Given this list of marker genes PPP2R3C, COPZ1, PALLD, ZFP91-CNTF, EME1, TK2, PARP10 (NCBI Gene Id 84875), ANTXR2, CDKL3, MRPS22, CTDSPL2, GIPR, MRPL54, PITPNM1, C2orf49, TNK2, CTDSPL2-DT, LARS1 (leucyl-tRNA synthetase 1), COQ10B, MAP2K7, SUB1, APOLD1, ENSA, RPS6, DYRK2, PPIL2, ZFHX3-AS1, EPM2A-DT, WDR54 (WD repeat domain 54), MIR616, CKS2, DSN1, CLIP1, GOLGA3, THOC6, ZSCAN29, ERLEC1, SLC25A23, SECISBP2L, PRDX5, NCOR2, DHRS7B, KATNB1, LINC01954, SEC31A, PARP2, ZSCAN5A, CATSPERG, C2orf49-DT, KMT5C, TPM1-AS, DHX34 (NCBI Gene Id 9704), ZNF628, DYNLT4, LINC02331, RPL37, MIR200CHG, FAM234A, GNRHR2, GABPB1-AS1, IGF2BP3, BRAF, DPY30, FBXL19, LASP1, RACK1, ZFP91, LARP4, PTCD1, SPRED2, GALE (UDP-galactose-4-epimerase), MRPS10, ASNS, TNFRSF1A, TMC3-AS1, TPR, KLHL8 (kelch like family member 8), PPP4R3B-DT, RDM1, LRRC31, NME1-NME2 (NME1-NME2 readthrough), CHTOP, CIC, TNPO3, ODR4, FEM1A, CREB3L4, PRPF38B, MIR200C, PTMA, MBD6, VCP, UNC5B-AS1, CHAC1, MAP3K11, SIK3, PISD, NAA38, SRSF1, TBP, PKIB, ETV6, BSDC1, NEAT1 (nuclear paraspeckle assembly transcript 1), DEPDC4, ERLIN2, TMEM201, TARS1, MIR148A, ZNF646, ZMAT5, NEDD4L, HOXA11-AS, MGAT2 (NCBI Gene Id 4247), LINC01392, IPO8, NAP1L5, TWNK, NCBP2AS2, SRP54-AS1, SNHG21, B9D1, COPG1, MRPS28, DNAJC14, NOTCH3, SLC28A2-AS1, SNORA9, MZT1, ITSN1, GCC1, TMEM198B, GALK2, SH3BP1, NACA, PITRM1, ZNF821, EBAG9, EMC3, CD27-AS1, MITD1, MLF2, FDFT1, BAZ2B, MIR194-2HG, SAMM50, DNASE1, TMEM267, WEE2-AS1, HSD3B7, ATP5MF-PTCD1, CCND2, UBE2Z, NT5C2, CLSTN1 (calsyntenin 1), ZSCAN5A-AS1, CEP70, RNU1-134P (RNA, U1 small nuclear 134, pseudogene), CENPS, UBL5, FOXK2, EIPR1, CNNM4, NPRL2, BRD4, EEF1AKMT3, KLHL28, SNX33, MRPL27, KRT7, WDR59, CCT2, SERF2, HOXA10-AS, SYNE3-AS1, CDC14A, SNHG15, RNU5E-1, ZNF398, SLC35A5, POLR1B, POLR1A, PFKL, AJUBA-DT, EED, PURB, TMCO1, BCAN-AS2, FKBP2, THAP7-AS1, PRR11, PPP4R3B, SRP54, HBP1, NCAPD2, PTPRO, HARS2, SLFN5, ZNF770, PDE4A, MRPL51 (mitochondrial ribosomal protein L51), ATP5MF, ZNF563, RPPH1, PSMD7-DT, UBQLN1, MRPL30, THAP9-AS1, TMED1, BCLAF1, RPS13 (NCBI Gene Id 6207), SNHG1, FBXL12, IST1, ENKUR, ATF6B, WDR75, METTL1, FNTB, LINC00431, MIR141, RPS19BP1, MOV10, MSMO1, ERP29, POC5, ZNHIT1, EPM2AIP1, HNRNPA0, PIGN, SKA2, GDF15, GRM8, LIMA1, BLOC1S2, FBXO30, PEX11B, CENPS-CORT, LRRC46, PCDH1, TRIB1, THAP9, MIR933, DPM1, PTCD3, AJUBA, PLOD3, BTBD19, NCBP2, ESRP2, STARD5, PRORP (protein only RNase P catalytic subunit), SCRN3, MLH1, SDR39U1, MOCS3, THAP7 (NCBI Gene Id 80764), TARS1-DT, TMEM253, ZNF668, ALAS1, RAB11A, MIR3913-1 (microRNA 3913-1), NDUFV3, C12orf76, TMEM18, PRMT2, SLC12A9, IBTK, MSL2, MAP1S (NCBI Gene Id 55201), TSEN2, UPF1, TNFRSF10A (TNF receptor superfamily member 10a), CNTNAP2, DLAT (NCBI Gene Id 1737), MANF, MARCKSL1P1, USP53 (NCBI Gene Id 54532), ABHD2, ARMT1, PPP6R2, HSDL2, ABHD12, H2AC8, CYB561D2, RELCH, FASN, NT5C3A, TRIM11, CAPRIN1, TPI1P2, RALY, SCYL2, C19orf38, RAB30, ATF2, FGGY, POP7, ASB3, ATP13A1 (ATPase 13A1), MCPH1-AS1, SNORD26, ZBTB1, HMGB2, MCCC1, WASL, PSMA2, PPIA, EMC3-AS1, AHCYL1, PRMT5, PLBD1, SLC25A21, RN7SL346P, TBL3, PSMD7, TAPBPL, SOCS5, SNORD25, NME1, EHMT2, RMND1, NDUFS4, AP3S1, ZBED5-AS1, THNSL1, SNORD95, HSPA5-DT, FPGS, GABPB1, SELENOI, RAB30-DT, PGGT1B, JUND, NR1D1, CCDC77, PCNX3, TOGARAM1, MIRLET7IHG, CCDC144NL-AS1, MPV17L2, LINC02026, HARS1, IP6K2 (NCBI Gene Id 51447), ERICH6-AS1, ANKRD17, AIMP1, SSBP1, PRMT5-DT, UBAP2L, IFT70A, DHX8, ADIPOR2, GEMIN2, CBR4-DT, ZNF440, LMNA, RPS3A, MRPL33, TRIM31 (NCBI Gene Id 88008), CKLF-CMTM1, UBAP1, RPL7P30, CABP1, MEA1, LTBR, RAPGEF6 (NCBI Gene Id 51735), ZBTB45, LPXN, FBXO33 (F-box protein 33), EIF3D (NCBI Gene Id 8664), NUP42, TNFRSF10A-DT, ERCC1 (ERCC excision repair 1, endonuclease non-catalytic subunit), ZBED5, SP1, CDK4, CKLF, SH3RF2, SNHG17, SDHD, ADGRF3, SERINC1, ZNF395 (zinc finger protein 395), KRT8, here is a description of the gene set: Genes containing one or more binding sites for (FOXO4) in their promoter regions (TSS -1000,+100 bp) as identified by GTRD version 20.06 ChIP-seq harmonization. Human Gene Set: FOXO4_TARGET_GENES from publication Yevshin I, Sharipov R, Kolmykov S, Kondrakhin Y, Kolpakov F (PMID 30445619) studied in species Homo sapiens